Given this list of marker genes VPS13B, NFKB1, TERF1, TMCC1, PIK3C2A, SLIT2, MTAP, PCNT, PTEN, TMEM131L, CUL2, NECTIN3, ATP2C1, UBXN7, TSC22D2, PLCB4, PHF14, WWP1, IL6, ATRN (NCBI Gene Id 8455), DOCK9, HEG1, AKAP10, SP100, NAV3, PTX3 (pentraxin 3), ATP8B1, PDLIM5, AVL9, IGF1R, ABCE1, PCCA, MALT1, ADCY9, AGO2, DKK1, FAM168A, ASXL1 (NCBI Gene Id 23393), RANBP2, SON, CDKN1B, MPHOSPH9, NALF1, PDS5B, DUSP5, ARAP2, VLDLR, ARHGEF10 (NCBI Gene Id 9639), CDH2, SMAD4, BMPR1A, AHDC1, RPS6KA3, SFMBT1, BDNF, BTRC, TGFBR3, BICD1, RB1CC1, FAM193A, HOXB2, GRK5, WDR37, DST, INTS3, CTIF, GSE1, TOGARAM1, SOS2, HERC4, AGFG1, DLG1, EIF3A, DLEU2, CENPC, ACAP2, ZEB2, GPATCH8, DOCK4, RALGAPB, E2F5, NFATC3, SLC25A12, MYO9B, PLCE1, here is a description of the gene set: species: Homo sapiens Human Gene Set: DACOSTA_UV_RESPONSE_VIA_ERCC3_XPCS_DN Genes exclusively down-regulated in fibroblasts expressing the XP/CS mutant form of ERCC3 after high dose UVC irradiation. from publication da Costa RM, Riou L, Paquola A, Menck CF, Sarasin A (PMID 15608684) Xeroderma pigmentosum (XP) and trichothiodystrophy (TTD) syndromes are characterized by deficiency in nucleotide excision repair pathway, but with distinguished clinical manifestations. While XP patients exhibit a high frequency of skin cancer, TTD patients are not cancer prone. The relation between lack of DNA repair and their clinical manifestations was investigated through analysis of the transcriptional profile of 12,600 transcripts in two isogenic cell lines with different capabilities of DNA repair. These cell lines result from a stable transfection of the XPB-TTD allele into XP complementation group B fibroblasts, from an XP patient who also have clinical abnormalities corresponding to Cockayne's syndrome (CS). The microarray assays performed under normal growth conditions showed the expression of distinct groups of genes in each cell line. The UVC-transcription modulation of these cells revealed the changes in 869 transcripts. Some of these transcripts had similar modulation pattern in both cells, although with eventually different time patterns for induction or repression. However, some different 'UVC signature' for each cell line was also found, that is, transcripts that were specifically UV regulated depending on the DNA repair status of the cell. These results provide a detailed portrait of expression profiles that may potentially unravel the causes of the different phenotypes of XP/CS and TTD patients.